Given this list of marker genes RPS6KA3, SP7, TCIRG1, SLC29A3, AKT1, XPA, TNFRSF11A, DDB2, ERCC5, ERCC3, TBXAS1, XPC (XPC complex subunit, DNA damage recognition and repair factor), LRP4, LRP5, SMAD4, KRAS, SOST, ERCC2, FLNA, GNAS, AMER1, ERCC4, PTDSS1, ANKH (ANKH inorganic pyrophosphate transport regulator), GJA1, NOTCH3, FGFR1, here is a description of the gene set: Excessive growth of the craniofacial bones. Craniofacial hyperostosis species: Homo sapiens Human Gene Set: HP_CRANIOFACIAL_HYPEROSTOSIS